Given this list of marker genes IKZF2, DLG5, SRI, BBX, NPR3, SCAF8, MAP3K1, CDC73 (NCBI Gene Id 79577), BTN2A1, MMRN2, RERGL, PIGN, PIGS, POLR3E, SERTAD4, HYCC2, TLCD4 (NCBI Gene Id 148534), CDADC1, PAPSS2, PPFIA2, SLC26A7, NUDT21, NDST3, CENPM, ROPN1, ENSG00000277067, QSER1, PSTPIP2, TUT4, AKAP6, ARIH1, LHFPL6, TTC17, DLG2, PDCD2, KIF24, RRM2, HEATR5A, XAF1, GPD2, AFF3, LMNB2 (NCBI Gene Id 84823), MBNL2, NXPH1, STARD4, PATL1, FLRT1, ARFGEF1, VPS13D, THOC2, CIBAR2, CLOCK, PAQR5, ITM2A, LINC03104, PPARGC1A, LINC03105, CADM2, OR13A1, TMEM47, ANKRD45, AMMECR1L, RRAS2, DNM1L, HEPACAM2, ANP32B, ATR, NUDT9, GPAM, RAB3C, PSME3IP1, GATA2, RAB10, PLA2G12A, MED6, GALNT13, here is a description of the gene set: from publication Chen Y, Wang X (PMID 31504780) Human Gene Set: MIR3613_5P Genes predicted to be targets of miRBase v22 microRNA hsa-miR-3613-5p in miRDB v6.0 with MirTarget v4 prediction scores > 80 (high confidence targets). studied in species Homo sapiens